The following is a description of a gene set: An organelle consisting of a network of tubules that functions in targeting molecules, such as receptors transporters and lipids, to the plasma membrane. Human Gene Set: GOCC_RECYCLING_ENDOSOME species: Homo sapiens, and this is the list of marker genes: VPS16, RAP2C, HLA-E, MICALL2, WASH6P, SNF8, HLA-B, VPS51, VPS33B, STX12, ACKR1, RAB11FIP3 (NCBI Gene Id 9727), WASHC1, SLC26A7, RAB25, AKAP5, VPS53, RAB11B, ZFYVE27 (NCBI Gene Id 118813), ABHD17C, TF, SCAMP3, SYT5, HLA-G, EHD2, ITGB1, VAMP8, DENND6B (DENN domain containing 6B), VPS26B, INPP5F, CD22, RABGEF1, ACAP1, RAB11FIP5, FCHSD2, AP1G1, GGA3, SLC9A7, STX8 (syntaxin 8), PDLIM4, PDIA3, AMOTL2, C1orf210, LAMP5, GPER1, HLA-H, EHD3, CFTR, SLC30A10, TMEM230, TPP1, SLC9A6, NSG1 (NCBI Gene Id 27065), DENND6A, RAC1, ABHD17A, AQP2, RAB10, EIPR1, FZD7, SNX27, NDRG1, RAB11FIP4, HLA-C, TFRC, VPS52, RELCH, VAMP3, CLTCL1, ARHGAP44, SLC31A2, RAB29, LDLRAP1, RAN, TUBGCP4, SCAMP2, ACKR2, RAB8A (NCBI Gene Id 4218), SLC9A3, SLC9A5, NISCH, SCAMP1, ANK2, PLA2G5, TNIK, VPS13B, SLC11A2, EHD1 (EH domain containing 1), PHETA2, HLA-A, RAB13 (RAB13, member RAS oncogene family), PLEKHA3, VTI1B, WIPF3, VPS50, ITSN1, SYT11, LZTR1, ATP11A, SORL1, RAB35 (RAB35, member RAS oncogene family), USP6, INPP4A, TUBG1, RFFL, RABEP1, PANK1, GRIPAP1, KCNK1, RAB8B, SNX18, SGK3, PHETA1, BAIAP3, TBC1D14, LMTK2, ACKR3, OPTN, RAP2B, RAP2A, AVL9 (NCBI Gene Id 23080), DYNC1I1, WASH3P, SLC39A4, PLEKHB2 (NCBI Gene Id 55041), GRIA1, C8orf44-SGK3, COMMD1, BOK, ABCG1, NTRK1, ATP13A3, RAB11A, ARF6, MTMR4, ATP11B, B2M (NCBI Gene Id 567), BACE1, SCAMP5, TBC1D12, CLCN3, ATG9A, CACFD1, MCTP1, ATP9A, VIPAS39, PLEKHJ1, ENTREP1, RAB11FIP1, CLN3, TPCN1, SLC9A9, SCAMP4, RAB17, AP3M1, TUBA1A, SLC31A1, FCHSD1, ACKR4 (atypical chemokine receptor 4), ST8SIA2, OR2A4, MICALL1, FIG4, RAB11FIP2, CLCN4, TNF, UNC13D, MYO5A, ZDHHC2, TMUB1, LTF, PLA2G3, HFE, APP, RAB4A, DENND2B, STX7, HLA-F, EEA1, SLC1A1, ARFGEF2, REP15, DNM2, MELTF, MLC1, ULK1, RAB4B, ABHD17B, CMTM6, SLC36A2, RAB14, DYNC1LI1, EHD4, ATP13A4, CD274, SLC9B2, RAB12, CLIP3 (NCBI Gene Id 25999), ENTR1, MCOLN2, MYO5B, RNF11, ATP11C (NCBI Gene Id 57206), SORCS2 (NCBI Gene Id 57537), ABCB11, GPR161, NEU3, RASSF9, STX6, TBC1D17, ATG9B, PACSIN2